Given this list of marker genes Dicer1, Igf1, Atg5, T, Calr, Cdc42 (NCBI Gene Id 12540), Nr3c1, Alpk2, Slc9a1, Akap13, Yap1, Adrb1, Xirp2, Tsc1, Rara (NCBI Gene Id 19401), Fzd7, Gata6, Jph2, Fadd, Smad1 (SMAD family member 1), Fkbp1a, Pdlim5, Adra1b, Frs2 (NCBI Gene Id 327826), Fdps, Foxh1, Sgcb, Fgfr2, Hnrnpu, Tgfb1, Hand1, Smad7, Bmp7 (NCBI Gene Id 12162), Foxc2, Col11a1, Wnt3a, Popdc2, Sorbs2, Tenm4, Mapk1, Angpt1, Arid2, Tnnc1, Myh11, Epo, Edn1, Smad4, Tpm1, Plec, Ski, Fhod3, Naglu, Myod1, Nog, Id2, Tgfbr3, Bmpr1a, Eng, Ep300, Trp73, Hamp, Gli1, Prkar1a, Ift20, 2810429I04Rik, Tbx18, Yy1, Arrb2 (NCBI Gene Id 216869), Klk1b1, Myo18b, Abl1, Maml1, Ctcf, Foxp1, Zic3 (NCBI Gene Id 22773), Gata4, Nox4, Myl2, Lmna, Med1 (NCBI Gene Id 19014), Tgfbr1, Ppara, Cav3 (NCBI Gene Id 12391), Foxc1, Pax3, Wt1, Fes, Erbb3, Sgcg, Heg1, Adra1a, Acvr1, Notch1, Bmp5, Tcap, Xirp1 (NCBI Gene Id 22437, xin actin-binding repeat containing 1), Zfpm2, Aldh1a2, Greb1l, Isl1, Nebl, Fhl2, AW551984, Hdac3 (histone deacetylase 3), Col14a1, Ctdp1, Mrtfb, Ptcd2, Ccnb1, Srf, Pdgfra, Ttn, Cited2, Slc8a1, Efnb2, Dll1, Dsg2, Kat2a, Met, Bmp4, Agtr2, Myh7, Kcnj11, Tnni1, Zfpm1, G6pdx, Myl7, Lrp6, Mybpc3, Tbx3, Pin1rt1, Ryr2, Gsk3b, Wnt2, Dyrk1a, Pim1, Lrrc10, Hdac2, Pin1, Nprl3, Mir1a-2, Trip10, Rbpj, Slc25a4, Mylk2, Pkp2, Sgcd, Tbx20, Pln, Hspg2, Rbp4, Map2k4, Mapk11, Myocd, Rgs4, Fgf3, Gja5, Egln1, Camk2d, Bmpr2, Cxadr (NCBI Gene Id 70446), Nkx2-5, Fgf9, Cby1, Ddx39b, Tafazzin, Sik1, Ctnnb1, Csrp3, Gsk3a, Kdm6b, Meis1, Ednra, Zfp418, Prox1, Gjc1, Mbd3, G6pd2, Ccm2l, Sin3b, Cacybp, Cdk1, Cripto, Tgfb2, Tbx2, Alpk3, Agt, Cavin4, Pten, Prickle1, Apc, Parp2, Creb1, Mir133a-2, Rbm10, Pdgfrb, Lrp2, Myh6, Vegfa, Rarb, Neb, Nrg1, Epor, Hey2 (hairy/enhancer-of-split related with YRPW motif 2), Ube4b (ubiquitination factor E4B), Mapk14, S1pr1, Bves, Dipk2a, Pou4f1, Myh10, Acadm, Dsp, Fgf8, Ppp1r13l, Adamts9, Hey1, Actc1, Nkx2-6, Dkk1, Mir208a, Sox6, Ndufv2, Rgs2, Nrap, Prmt1, Sav1, Fgf1, Shox2, Mylk3, Sirt6, Irx3, Adprhl1, Itgb1, Trex1, Jarid2, Ang2, Akap6, Tbx1, Grem1, Tomm70a, Prkg1, Dll4, Mbd2, Fgf2, Mir133a-1, Speg, Rxrb, Actn2 (actinin alpha 2), Kcnk2, Bvht, Erbb4, Bmp2, Mecp2, Large1, Ly6e, Zmpste24, Fgfr1, Atg7 (autophagy related 7), Kcnj8, Mtor, Bmp10, Tnnt2, Mef2c, Myl3, Ankrd1, Sirt1, Hand2, Casp8, Vgll4, Sgcz (NCBI Gene Id 352972), Ccn4, Ccnd2, Pi16, Mef2a, Tbx5, Rxra, 3425401B19Rik, Tgfbr2, Asb2, Gja1, Tnni3, Pak1, Gata5, Arid1a, Pitx2, Hamp2, Mesp1, Ncam1, Chd7, Ift88, Fgf20, here is a description of the gene set: Mouse Gene Set: GOBP_CARDIAC_MUSCLE_TISSUE_DEVELOPMENT The process whose specific outcome is the progression of cardiac muscle over time, from its formation to the mature structure. studied in species Mus musculus